The following is a description of a gene set: Human Gene Set: TGGTGCT_MIR29A_MIR29B_MIR29C Genes having at least one occurence of the motif TGGTGCT in their 3' untranslated region. The motif represents putative target (that is, seed match) of human mature miRNAs hsa-miR-29a, hsa-miR-29b and hsa-miR-29c (v7.1 miRBase). studied in species Homo sapiens, and this is the list of marker genes: EML4, EML5, SESTD1, PDGFRB, DDX11, BIRC6, ADAMTS13, KMT5C, CORO6, QKI, MLLT11, PCYT1B, ERLIN2, PPP1R3D, HNF4G, RNF138, SMPD3, GPR37, FAM131B, PIK3R3, MFSD14B, OSBP, PHC1, SLC39A9, ARNT, LOXL4, WDFY3, ABCE1, SH3PXD2A, CCNYL1, INSIG1, SH3BP5L, CRYBG2, TAF5, SYT8, AFF4, MEX3B, SFPQ, RASGRP4, EIF4E2, CLK2, SPTY2D1, CLDN1, SPAST, ZNF282, KCNMA1, PCGF3 (NCBI Gene Id 253443), STX17 (NCBI Gene Id 9485), MFAP3, SPTLC2, CCND2, HAS3 (hyaluronan synthase 3), MLF1 (NCBI Gene Id 4291), KCTD5, PALM, ISL1, GRM4, LUZP1, CTNNBIP1, YTHDF3, IFI30, RAB15, NFATC4, PCDHAC2, LAMC1, DAB2IP, SIDT1, ZNF362, PCDHA4, TMEM65, KIF3B, ZNF385C, RIC8A, POU2F2, TMPRSS3, RAB30, BRWD1, RCC2, COL19A1, IMPDH1, PPP1R15B, EDC3, RNF39, FBN1, BRWD3, NCOA4, SNX4, NLGN3, PCDHA8, PCDHA5, ADAMTS6, COL3A1, PTHLH, NKRF, FAM193B, JOSD1, STAG2, PTEN, PPARGC1A, TRIM63, KCTD15, CDK6, CALM3, CAV2, PCDHA12, RET, AMER1, CHFR, IREB2, NPAS4, WDFY1, TMEM266, HMGCR, HEPACAM, TRIM37, NCOR2, ANK3, PCDHA13, HAPSTR1, DCUN1D4, SSC4D, DNMT3A, LPL, PLEKHA1, KIRREL1, HECW1, MTMR4, PLPPR5, XPO5, ADAM12, PAIP2, SHROOM2, NAV3, PARG (poly(ADP-ribose) glycohydrolase), ATP5MC1, RAB40C (NCBI Gene Id 64715), XKR6, COL5A3, SNX24, C11orf87, DAG1, PRR3, ZER1, ABHD4, EPHB3, PITPNA, PCDHA1, BCL11B, PTBP3, DGKD, SLC30A3, FBXW9, SENP1, CD276, BAIAP2, PER3, ERP44, PCDHAC1, ZNF346, ZBTB40 (NCBI Gene Id 9923), DEF8 (NCBI Gene Id 54849), COL9A1, C5orf24 (chromosome 5 open reading frame 24), GPX7, MUC4, BAK1, HBP1, TTYH2, ATP1B1, BMF, IGF1, DIO2, FERMT2, TSC22D3, MAT1A, NFASC, NDRG4 (NCBI Gene Id 65009), HIF3A, NAV1, OXR1 (oxidation resistance 1), VASH2, ELMO2, DIAPH2, COL4A1, KLHL25, ARRDC4, NAA40, DIABLO, SLC31A1, C5orf15, VPS36, FAM136A, KLF12, SOX12, ETV4, FRAS1, SGK1, RYBP, YPEL2, TMEM132A, INO80D, ITGB1, DDX3X, SETDB1, PGAP2, PPP4R3B, CRISPLD1, AP1G1, PEX5, LEP (NCBI Gene Id 3952), CELF6, C1QTNF6, IGSF9B, ATRN, NFAT5, ZFP91, BCL9L, ELOVL4, CAMTA1 (calmodulin binding transcription activator 1), MBLAC2, IFNG, CHIC2, KDM2A, STARD5, DICER1, SRGAP2, NREP, CPNE8, ATG9A, CAMK2G, MAP6, SLC16A14, AMOT, USP42, PCDHA7, TNFRSF1A, KMT2A, MYL6, TRAFD1, COL15A1, BRD4, COL1A1 (collagen type I alpha 1 chain), N4BP2L1, COL11A1, CBX2, YY1, ARRDC3, MED12L, COL4A2, CNR1, CCDC117, GREB1L, PAN2, ZFYVE26, MFAP2, KLHL30, ARK2C, SMARCC1, TMED9 (NCBI Gene Id 96645), VPS9D1, ZBTB5, TMUB2, RAPGEFL1, VEGFA, ADAMTS9, PCDHA10, HYCC2, DOLPP1, KCNIP2, MAFB, NKAPD1, STARD8, LARP4B, TMEM255A, AGPAT4, WDR26, RND1, TMEM86A, TPM1, OSBPL11, ANKRD13B, COL5A2, ZBTB47, TMEM183A, PURA, LSM11, HNRNPUL1, NAV2, ANKRD49, PCDHA9, ZFP36, CMPK1, TMEM169 (NCBI Gene Id 92691), FBRS (fibrosin), MYCN, KBTBD8, TFEB, SYPL2, COMMD2, PTP4A1, CA3, BACH2, PPIC, CTNND1, ATP2B1, EPS15 (epidermal growth factor receptor pathway substrate 15), FBXW7, TUBB2A, GLIS2 (GLIS family zinc finger 2), SPPL2B, FEM1B, ACVR2A, PSME4, CAPRIN1, PCDHA6, TNFAIP1, GPCPD1 (NCBI Gene Id 56261), GCC2, ESYT3, TRIB2, MMP2, FBXO24, HS3ST3B1, ELF2, PPARD, SOCS1 (suppressor of cytokine signaling 1), COL16A1, RMND5A, FOS, TUBB2B, SPRY1, PPP2CA, DIP2B, AGO1, ENHO, DUSP2, EXOC3L1, ZFX, TET1, SCML2, ZBTB41, SYNE1, PRKAB2, COL4A5, NKTR, RNF19A, AMMECR1L, NDST1, SMS, SP1, CPEB3, PMP22, IL1RAP, PCDHA2, ARMC8, HTR7, YBX3, TMEM259, SKI, NCOA3, PIK3R1, ZBTB46, NAP1L3, PURG, GAB1, POGLUT2, DBT, BCL11A, MINAR1, GMFB, PCDHA11, EPB41L4B, PI15, NFIX, KMT5B, ZDHHC5, HPS1, PRICKLE2, CAMK1D, GOPC, CACNG4, RAB6B, DNAJB11 (DnaJ heat shock protein family (Hsp40) member B11), LGI2, PLP1, CTDSPL2, CALU, NANP, BMP1, ADAMTS18, DNM3, DPF1, PDIK1L, TLCD3B, MAFG, HMGCS1, PCDHA3, SLC16A1, VPS25, IFFO1, XKR7, CLUH, ASPH, TMTC3, KLF4, RLF, RAP1GDS1, R3HDM4, PPM1D, PROSER1, KDM5C, BCORL1, EMSY, SLC1A2, STX1A, HDAC4, ATXN1, COL6A3, TDG, LIF, MYBL2, STRN3 (striatin 3), EPHA3, LYSMD1, MAPKBP1, ADAM19, OXTR, PRELP, KLHDC3, ALKBH6, COL4A4, TLL1, NEXMIF, RHOT1, FOXJ2, KPNA4, MMP24, ABCB6, MORF4L1, AP4E1 (NCBI Gene Id 23431), ABCB9, BCL7A, KLHL42, NRSN1, RGPD5, HMGN3, CDC42, ARVCF, DCAF7 (NCBI Gene Id 10238), SPTAN1, TMEM127, ATP2B4, SHPRH, SYNE4, CHSY1, CREB5, DENND6A, GNG12, BLMH, MAP4K4, MIDEAS, CCSER2, DENND1B, PER1, TSPAN4, GID4, HMCN1, PPP1R13B, ARPP19, ZNF512B, DGKH, ZNF524, NFIA (nuclear factor I A), ANKRD13C, USP37, CEMIP, SRGAP3, FAAP100, PGAP1, COL2A1, GPAM, CSRNP2, ZFP36L1, DCX (NCBI Gene Id 1641), OTUD4, PDGFB, CAPN7, AKAP13, MAT2A, AHR, SPEN, PDHX, PPM1E, RARB (NCBI Gene Id 5915), ZNF609, COL4A3, NSD2, GARRE1 (granule associated Rac and RHOG effector 1), RTL6, RND3, STRN4, COL7A1, LDLRAP1, PLAG1, PITPNM2, SS18L1, FAM167A, MGAT4B, TRAF4, XKR4, REV3L, MORF4L2, PRKRA, ASIC1, LAMTOR1, CCNT2, SBF2, AKT3, FAM13B, NASP